Given this list of marker genes CD4 (CD4 molecule), PPP3CA, ITPRIP, NR4A1, NFATC2, PPP3CC, HDAC1, CD8A, ZAP70, CABIN1, LCK, PLCG1, PPP3CB, CALM1, CAPN2, HDAC2, EP300, CD8B, MEF2D, ATP2A1, here is a description of the gene set: species: Homo sapiens Human Gene Set: WP_CALCIUM_MEDIATED_TCELL_APOPTOSIS_INVOLVED_IN_INCLUSION_BODY_MYOSITIS Calcium mediated T-cell apoptosis involved in inclusion body myositis